The following is a description of a gene set: Mouse Gene Set: GOBP_VEIN_SMOOTH_MUSCLE_CONTRACTION studied in species Mus musculus A process in which force is generated within smooth muscle tissue, resulting in a change in muscle geometry. This process occurs in the vein. Force generation involves a chemo-mechanical energy conversion step that is carried out by the actin/myosin complex activity, which generates force through ATP hydrolysis. The vein is a vessel carrying blood away from the capillary beds., and this is the list of marker genes: Edn2, Edn1, Htr7, Ednrb, Edn3